Given this list of marker genes INS, LEPR, USP7, C1QTNF12, TCF7L2, KAT2A, PGP, CRY1, C1QTNF3, CLK2, ADIPOQ, SERPINA12 (serpin family A member 12), MTCL2, EP300, SIK1, SIRT6, MST1, NR0B1, ERFE, GCK, here is a description of the gene set: Any process that stops, prevents, or reduces the frequency, rate or extent of gluconeogenesis. studied in species Homo sapiens Human Gene Set: GOBP_NEGATIVE_REGULATION_OF_GLUCONEOGENESIS